The following is a description of a gene set: electronically inferred by orthology from the curated human pathway studied in species Mus musculus Reactome Pathway: Transcriptional regulation of white adipocyte differentiation part of: Adipogenesis This event has been computationally inferred from an event that has been demonstrated in another species.<p>The inference is based on the homology mapping from PANTHER. Briefly, reactions for which all involved PhysicalEntities (in input, output and catalyst) have a mapped orthologue/paralogue (for complexes at least 75% of components must have a mapping) are inferred to the other species., and this is the list of marker genes: Pparg, Hdac3, Ncor2